The following is a description of a gene set: species: Homo sapiens Any process in which a protein is transported to, or maintained at, the telomeric region of a chromosome. Human Gene Set: GOBP_PROTEIN_LOCALIZATION_TO_CHROMOSOME_TELOMERIC_REGION, and this is the list of marker genes: ZNF827, XRCC5, PML, TERF1, PINX1, SPDYA, ACD, BRCA2, TERF2IP, TERT, TINF2, TNKS, NABP2, POT1, CCT6A, ATR, USP7, GNL3, TNKS2, WRAP53, TERF2, GNL3L, ATRX, TPP1, MACROH2A1, TCP1